The following is a description of a gene set: Human Gene Set: GOBP_NEGATIVE_REGULATION_OF_SYNAPTIC_TRANSMISSION Any process that stops, prevents, or reduces the frequency, rate or extent of synaptic transmission, the process of communication from a neuron to a target (neuron, muscle, or secretory cell) across a synapse. studied in species Homo sapiens, and this is the list of marker genes: PCDH17, DRD3, GABBR1, ARC (activity regulated cytoskeleton associated protein), TNR, LILRB2, SLC6A4 (NCBI Gene Id 6532), SRF, AGER, GRID2IP, SHANK3, ADIPOQ, PMCHL2, TPRG1L, GRIK2, IL1B, ABHD6, PICK1, SLC24A1, DRD1, SLC24A2, HTR2A, ADNP, MAPT, STAU2, CBLN1, PRRT1, GRM2, KCNB1, STXBP1, PLK2, ATAD1, DRD2, BCHE, NPY2R, ACHE, ADCY8, CNR2, NPY5R, PRKN, PENK, VPS13A, SORCS2, PMCH, GRIK3 (NCBI Gene Id 2899), ARF1, GNAI2, FMR1, GRID2, SORCS3 (NCBI Gene Id 22986), SHANK2, GRIA1, DRD5, CD38, ADORA1, HCN1, IQSEC2